The following is a description of a gene set: studied in species Homo sapiens Human Gene Set: HP_ABNORMAL_SCROTUM_MORPHOLOGY Any structural abnormality of the scrotum, i.e., the sac that contains the testes, epididymis, and the lower part of the spermatic cord. Abnormal scrotum morphology, and this is the list of marker genes: SNORD116-1, ORC1, BMP4, TSPYL1, HMGA2, NSUN2, OPHN1, PWAR1, H19, NR5A1, LMX1B, STT3B, RAB3GAP2, HERC2, TUBB, CILK1, FARSB, FGFR2, HSD3B2, CDKN1C, PSMD12, MAPRE2, MTM1, EFNB1, SRCAP, CHD7, LAMA5, BLTP1, ZEB2, RSPO2, SRY, ALX4, TOE1, MAMLD1, DHX37, GRIP1, TRIM28 (NCBI Gene Id 96054), RYR1, SAMD9, HOXA13, BRCA2 (NCBI Gene Id 82716), IGF2, IER3IP1, TMCO1, ANOS1, NECTIN1, SOX9, KRT5, CYB5A, SETBP1, TRIP13, PHF6, TBC1D20, WWOX, MEGF8 (NCBI Gene Id 90198), PSENEN, FGD1, GPC3, DIS3L2 (DIS3 like 3'-5' exoribonuclease 2), MYRF, KAT6B, BUB1B, ORC6, FREM2, FRAS1, WNT3, HNF1B, OCA2, DACT1, DYRK1A, POLR1B, NDN, DHCR7, TCOF1, POLR1D, KIFBP, PTRH2, MID1, ATRX, CDH11, RAB18 (RAB18, member RAS oncogene family), ACTB, ARCN1, MED12, POU6F2, TBX4, STT3A, PLAG1, NEXMIF, PWRN1, IRF6, WT1, VAMP7, ERCC2, SPTBN1, CYP17A1, UPB1, NR0B1, TWIST2 (NCBI Gene Id 117581), CREBBP, MAP3K1, MINPP1, SIM1, MYH3 (myosin heavy chain 3), FAT4, SRRM2, MAGEL2, POLR1C, HOXD13, SRD5A2, LHX1, MKRN3, SNORD115-1, SALL1, SNRPN, COLEC10, POGLUT1, STXBP1, GLI3, EP300, FLI1, METTL23, PTEN, ALG12, POFUT1, SPECC1L, SLC25A24, GATA4, TRRAP, RFX7, REST, CHRNG, FZD2, SEMA3E, NPAP1 (nuclear pore associated protein 1, NCBI Gene Id 23742), MAB21L1, PNPLA6, ZFPM2 (NCBI Gene Id 56958), WNT7A (Wnt family member 7A), POR, AKT1, AR, TBX3